The following is a description of a gene set: species: Homo sapiens The directed movement of L-glutamine from outside of a cell, across the plasma membrane and into the cytosol. Human Gene Set: GOBP_L_GLUTAMINE_IMPORT_ACROSS_PLASMA_MEMBRANE, and this is the list of marker genes: SLC38A2, SLC38A3, SLC38A1, SLC1A5, SLC38A5